Given this list of marker genes SELENOK, NAA15, MAGEA2 (NCBI Gene Id 83160), NAA60, XBP1, PPM1B, NAT10, NAA11, ZDHHC1, DIP2B, EP300, HHATL, NAA16, HHAT, ESCO2, ZDHHC14, BAG6, ZDHHC11, NAA80, CREBBP, NAA10, MAGEA2B, PPM1A, KAT6A, MBOAT4, SPHK1, NAA50, ZDHHC5 (NCBI Gene Id 25921), PORCN, KAT5, NAT8, ZDHHC16, NAT8B, CLOCK, ZDHHC18, CLIP3 (CAP-Gly domain containing linker protein 3), NMT2, NAA20, AANAT, KAT7, GTF2B, ZDHHC23, GOLGA7, FOXO1, HAT1, ZDHHC20, GLUL, KAT2B, DIP2A, ING4, ZDHHC22, ZDHHC9, NMT1, ZDHHC8, ZDHHC3 (zinc finger DHHC-type palmitoyltransferase 3), ZDHHC15, ZDHHC6, KAT2A, ZDHHC7, SIRT1 (NCBI Gene Id 23411), ZDHHC21, ZDHHC19, ATAT1, CDYL, ZDHHC17, ZDHHC12, DSCC1, ESCO1, ING5, BMAL1, FAM161A, KLF15, BLOC1S1, ZDHHC2, CEP295, here is a description of the gene set: Human Gene Set: GOBP_PROTEIN_ACYLATION The addition of an acyl group, any group or radical of the form RCO- where R is an organic group, to a protein amino acid. species: Homo sapiens